The following is a description of a gene set: B lymphoma expression clusters. species: Homo sapiens Human Gene Set: MODULE_456, and this is the list of marker genes: PDGFD, CR2, SELE, AGO2, GPR65, CBLN1 (NCBI Gene Id 869), ASB13, TSPAN7, DENND3, SH2D2A, CD83, SWAP70, TRIB2, MICAL2, BASP1, CREM, NRAS, FAM169A, RGL3, POLD3, PAG1, HIF1A, STARD4, DUSP5, MAL, CCPG1, RIPK3, MAPK10, TLR1, GMPS, KLRK1, MME, TRAF1, PRKCH (protein kinase C eta), PIF1, SIDT1, ATF6, TNFRSF25, ZNF652, EVI2A, IL1B, PTK7, NR4A3, MSX1 (NCBI Gene Id 4487), NFKB2, MYBL1, PCNA, DDA1, MMRN2, NFKBIA, HASPIN, CHI3L2, TOX, CYTIP, LCK, STAG3, GFOD3P, KLHL15, LINC00160, NOX4, YIF1B, SORL1, NPIPB3, HYCC1, CTTNBP2NL, CDKN2C, CD1C, STX11, SLAMF1, SLC43A3, OAS3, IFIT1, BHMT2, SAMSN1, DNAJC12, ANPEP, STAT4, MED29, SON, SLC2A3, BCL6, MGLL, MMD, SCAND2P, TNFAIP3, IL6, FYN, PTGER4, CCNE2, HSPA5 (heat shock protein family A (Hsp70) member 5), CD38 (NCBI Gene Id 952), SATB1, SRSF5, TRIB3, IL6ST, CDKN1A, KLHL6, ZNF16, ATP2C1, GJB2, BCL7A, APOA2, TNF, CD8A, PRKAR2B, GSTM1, A4GALT, GCC2 (GRIP and coiled-coil domain containing 2), BMP7, CYP2E1, ZNF608, DTX1 (NCBI Gene Id 1840)